The following is a description of a gene set: species: Mus musculus Ion transport by P-type ATPases Mouse Gene Set: REACTOME_ION_TRANSPORT_BY_P_TYPE_ATPASES, and this is the list of marker genes: Atp1b1, Atp2c2, Atp13a1, Atp1a3, Atp13a2, Fxyd1, Atp2b4, Calm3, Atp13a4, Sri, Atp9b, Atp2b3, Atp8a2, Fxyd2, Atp4a, Atp7a, Calm1, Fxyd3, Atp13a5, Pln, Fxyd6, Atp1b2, Atp11a, Camk2a, Atp8b4, Atp7b, Fxyd7, Atp2c1, Camk2d, Atp2a1, Atp1a4, Atp8a1, Atp11c, Camk2b, Atp10b, Atp2a3, Atp11b, Camk2g, Atp10d, Atp10a, Fxyd4, Atp4b, Atp8b2, Atp2b1, Atp9a, Atp1a1 (NCBI Gene Id 229653), Pdzd11, Atp12a, Atp8b3, Atp2b2, Calm2, Atp8b1, Atp2a2, Atp1a2, Atp1b3